The following is a description of a gene set: studied in species Homo sapiens Human Gene Set: GOBP_RESPONSE_TO_INTERLEUKIN_1 Any process that results in a change in state or activity of a cell or an organism (in terms of movement, secretion, enzyme production, gene expression, etc.) as a result of an interleukin-1 stimulus., and this is the list of marker genes: IKBKB, IGBP1, IL6, CCL2, IRAK1, PYCARD, GCLC, HYAL1, PRKCA, INHBB, SFRP1, NFKBIA, EDN1, MAP2K7, PRKCI, UPF1, MAP3K7, MAPK3, CEBPB, PLCB1, EGR1, VRK2, SELE, IL1RAP, CD40, MYLK3, MIR146A, IRAK2, RORA, CD38, GHR, NKX3-1, CXCL8, TAF9, MIR142, YTHDC2, RBMX, RELA (RELA proto-oncogene, NF-kB subunit), ZNF675, ANKRD1, SNCA, SIGIRR, LGALS9, RPS6KA4, MIR204, ADAMTS7, OTUD4, MIR101-1, ADAMTS12, IL1RN, CD47, TAX1BP1, IL17A, YY1, MYD88, GBP1, MAPK11, PTGIS, MIR21 (microRNA 21), KLF2, SIRPA, IL1B, RC3H1, RIPK2, PYDC1, BMI1, CCL3, TRAF6, DAB2IP (NCBI Gene Id 84635), NR1D1, TNFRSF11A, KMO, APP, FGB, HYAL2, CACTIN, HES1, MIR27A, LCN2, GBP3, SLC30A8, ACOD1, ZBP1, IRAK3, MMP2, IL1R2, NLRP7, USP10, HAS2, CAMP, IRAK4, HIF1A, SOX9, IL1R1, MTHFR, MIR766, HDAC4, CFL1, TLE5, TOLLIP, AKAP12, ST18, TANK, SMPD1, CITED1, IL1RL2, CCL5, MAPK13, SRC, RPS6KA5, HYAL3, CYBA, TRIM63, TNIP2, CHI3L1, GBP2, EPO (erythropoietin), ZC3H12A